The following is a description of a gene set: Human Gene Set: GOBP_PHENOL_CONTAINING_COMPOUND_METABOLIC_PROCESS species: Homo sapiens The chemical reactions and pathways involving a phenol, any compound containing one or more hydroxyl groups directly attached to an aromatic carbon ring., and this is the list of marker genes: NPR1, SLC16A2, SLC26A7, DBH, PNKD (PNKD metallo-beta-lactamase domain containing), CRYM, SLC16A10, SLC6A3, NPY, TRPC1, ABAT, RNF180, CYP1A1, GCH1, ZEB2, SLC5A5, SULT2A1, FAH, DIO2, RAB38, TH, NT5DC2, PAX8, EDNRA, SULT1B1, MOXD2P, COMT, SULT1A2, ASIP, CTNS, MED1, SLC7A11, DDC, PARK7, PNMT, DRD4 (dopamine receptor D4), ALDH2, GRIN2A, GCNT4, HPN, RTL4 (retrotransposon Gag like 4), CITED1, MAOA, DAO, SLC45A2, SLC1A1, CTSK (NCBI Gene Id 1513), SNCAIP, SLCO1C1, CDH3, INSM1, TG, NR4A2, CPQ, MOXD1, KL, PMEL, TPH2, ITGAM, TGFB2, HDC, HAND2, TPH1, SNCA, PDE1B, BCL2, DUOXA2, DRD2, VPS35, TPO, WNT5A, CTSB, CHRNB2, AOC2, TYR, DRD1 (dopamine receptor D1), TACR3, SNCB, DUOXA1, MC1R, MAOB, GNAT2, GIPC1, DDT, OCA2, FOXE1, OPN3, DCT, DIO1, PAH, PRKN, HTR1A, SULT1A1, GATA3, SULT1A4, IYD, DUOX1, CYP2E1, EPAS1, APPL1, ATP7A, SRD5A1, BTBD9, CGA, DUOX2, HPRT1, ITGB2, SLITRK1, RAPGEF2, DRD3, TYRP1, DIO3, SLC24A5, MFSD12, SULT1A3, GPR37